Given this list of marker genes HADHA, CIITA, ETS1, GBP1, MKNK1, CD1C, RPA1, SPI1, IL4R, TNF, MSH2, MYC, LTB, SNRPC, CSTF2, TRAF5, BLK, REL, RAE1, RHOG, ID3, OGG1, CCNG2, HRAS, FOXM1 (NCBI Gene Id 2305), SPIB, CXCR5, CDC20, SLC7A6, ELF1, EGR3, EED, RHOH, TERF2, RUNX3, ABCD3 (NCBI Gene Id 5825), CD1D, LMNB1, CCNF, ITSN2, VCL, LIG1 (NCBI Gene Id 3978), here is a description of the gene set: Human Gene Set: ZHAN_EARLY_DIFFERENTIATION_GENES_DN from publication Zhan F, Tian E, Bumm K, Smith R, Barlogie B, Shaughnessy J Jr (PMID 12393520) studied in species Homo sapiens B lymphocyte early differentiation genes (EDG): top genes down-regulated in tonsil B lymphocytes (TBC) compared to the tonsil plasma cells (TPC). To identify genes linked to normal plasma cell (PC) differentiation and to classify multiple myeloma (MM) with respect to the expression patterns of these genes, we analyzed global mRNA expression in CD19-enriched B cells (BCs) from 7 tonsils, CD138-enriched PCs from 11 tonsils, 31 normal bone marrow samples, and 74 MM bone marrow samples using microarrays interrogating genes. Hierarchical clustering analyses with genes clearly segregated the 4 cell types, and chi-square and Wilcoxin rank sum tests (P <.0005) identified 359 and 500 previously defined and novel genes that distinguish tonsil BCs from tonsil PCs (early differentiation genes), and tonsil PCs from bone marrow PCs (late differentiation genes), respectively. MM as a whole was found to have dramatically variable expression of EDGs and LDGs, and one-way analysis of variance (ANOVA) was used to identify the most variable EDGs (vEDGs) and LDGs (v1LDG and v2LDG). Hierarchical cluster analysis with these genes revealed that previously defined MM gene expression subgroups (MM1-MM4) could be linked to one of the 3 normal cell types. Clustering with 30 vEDGs revealed that 13 of 18 MM4 cases clustered with tonsil BCs (P =.000 05), whereas 14 of 15 MM3 cases clustered with tonsil PCs when using 50 v1LDG (P =.000 008), and 14 of 20 MM2 cases clustered with bone marrow PCs when using 50 v2LDG (P =.000 09). MM1 showed no significant linkage with normal cell types studied. Thus, genes whose expression is linked to distinct transitions in late-stage B-cell differentiation can be used to classify MM.